Given this list of marker genes RABEP2, STAG2, TMEM92, TMEM135 (transmembrane protein 135), APOBEC4, RNF103, STAC2, ZNF277, YIPF5, BASP1, PAIP2, MORF4L1, ZNF710, GDAP2, CLMN, KCNC3, LRCH4, PEPD, H2BC13 (NCBI Gene Id 8340), HERC1, C3orf70, ATOX1, NADK, STAT5A, ARHGAP5, AGO4, ACTN1 (NCBI Gene Id 87), CYBB, MAP1LC3B, SQSTM1, FAM161A, PHF14, IK, CDH4, MAP3K1, MOSPD2, EZH1, FLNA, PRKAB2, SNX20, MYPN, TNFRSF13B, HINT3, VIM, AIF1L, GLUD1, GPR26, PCDH8, SCN2A, RAB7A, AKR7A2, NFATC2, FTMT, ASPG, FILIP1L, CD52, SVIL, PGLYRP1, PLEKHB1, MBD2 (NCBI Gene Id 8932), IGFBPL1, SASH1, UVSSA, RCOR3, SIKE1, GPR35, LY9, UBXN2A, TBC1D22A, PLP1, ELAC1, ARID4A, RENBP, SCNN1B (NCBI Gene Id 6338), PTPRE, FAM91A1, SCAI, KBTBD7, MBIP, OVOL1, TBC1D23, EPHA4, CMYA5, SYNGR3, CDON, PTPRT, CIMIP6, SH3BGRL, MOB4 (MOB family member 4, phocein), CSF2RA, ANO1, MCUR1, IFNAR1, KIF9, MYO9A, CNOT6L (CCR4-NOT transcription complex subunit 6 like), CAMK1D, MCUB, ISX, TAFAZZIN, CFH, GAB3, WNT2, E2F5, NR3C1, LY6D, CREBRF, ZNF536, C5, EPS8, DOCK2, HTR7, PNRC1, FXR1, SDCBP, IGLC7, CORT, A4GALT, DBN1, SELENOO, LACTBL1, GPR107, PKD2, MUC5B, IFI30, PPM1E, MTMR10, STX5, GNAI3, PHOX2A, TAF13, NSD3, RNF150, PTP4A2, NIBAN1 (niban apoptosis regulator 1), REEP3, CCNY, ART1, EXOC7, PPM1K, IL6ST, DTX2, CYP4V2, TOX4, MFAP3, TNS3, DUSP16, CD72, CDC42BPB, JUNB, ARF6 (NCBI Gene Id 63379), AMZ1, FICD, PIAS1, SCTR, ACP5, LRRC18, MAPK14, TMEM50B (NCBI Gene Id 757), ATP6V0E2, RNF185, DIRAS1, ESCO1, CPSF3, STK38L, SLC66A1, NFAM1, RNF180, DYNC1I2, STARD9, GGT1 (NCBI Gene Id 91347), PRXL2C, RP2, TRIM7, IFNGR1, SDK1, MYADM, PBX3, NDST3, TMEM86A, BMPR2, LPAR4, HNRNPAB, SCRN1, CAST, ITGA4, ATXN7L3B, PHOSPHO2, TRAPPC8, C5orf63, GPR68, COMMD6, SIK3, SNX8, ANKRD12, ANXA2, SENP7, HERPUD1, ARL4C, here is a description of the gene set: from publication Szanto A, Balint BL, Nagy ZS, Barta E, Dezso B, Pap A, Szeles L, Poliska S, Oros M, Evans RM, Barak Y, Schwabe J, Nagy L (PMID 21093321) Conditional macrophage-specific PPARg knockout mice were generated on C57Bl/6 background by breeding PPARg fl/- (one allele is floxed, the other is null) and lysozyme Cre transgenic mice. PPARg and IL-4 signaling was analyzed on bone marrow-derived macrophages. Bone marrow of 3 mice per group was isolated and differentiated to macrophages with M-CSF (20 ng/ml). 20 ng/ml IL-4 was used to induce alternative macrophage activation and 1 uM Rosiglitazone (RSG) was used to activate PPARg. From each mouse 4 samples were generated: 1. M-CSF, 2. M-CSF+RSG, 3. IL-4 and 4. IL-4+RSG. All compounds were added throughout the whole differentiation process, and fresh media was added every other day. Control cells were treated with vehicle (DMSO:ethanol). After 10 days, RNA was isolated and gene expression profiles were analyzed using Mouse Genome 430 2.0 microarrays from Affymetrix. Genes down-regulated in bone marrow-derived macrophages with PPARG knockout: control versus rosiglitazone. Human Gene Set: GSE25123_CTRL_VS_ROSIGLITAZONE_STIM_PPARG_KO_MACROPHAGE_DN species: Homo sapiens